The following is a description of a gene set: Somatic cells can be reprogrammed to a pluripotent state through the ectopic expression of defined transcription factors. Understanding the mechanism and kinetics of this transformation may shed light on the nature of developmental potency and suggest strategies with improved efficiency or safety. Here we report an integrative genomic analysis of reprogramming of mouse fibroblasts and B lymphocytes. Lineage-committed cells show a complex response to the ectopic expression involving induction of genes downstream of individual reprogramming factors. Fully reprogrammed cells show gene expression and epigenetic states that are highly similar to embryonic stem cells. In contrast, stable partially reprogrammed cell lines show reactivation of a distinctive subset of stem-cell-related genes, incomplete repression of lineage-specifying transcription factors, and DNA hypermethylation at pluripotency-related loci. These observations suggest that some cells may become trapped in partially reprogrammed states owing to incomplete repression of transcription factors, and that DNA de-methylation is an inefficient step in the transition to pluripotency. We demonstrate that RNA inhibition of transcription factors can facilitate reprogramming, and that treatment with DNA methyltransferase inhibitors can improve the overall efficiency of the reprogramming process. Genes with low-CpG-density promoters (LCP) bearing the bivalent tri-methylation marks at H3K4 (H3K4me3) and H3K27 (H3K27me3) in MCV8.1 cells (induced pluripotent cells, iPS). species: Mus musculus Mouse Gene Set: MIKKELSEN_IPS_LCP_WITH_H3K4ME3_AND_H3K27ME3 from publication Mikkelsen TS, Hanna J, Zhang X, Ku M, Wernig M, Schorderet P, Bernstein BE, Jaenisch R, Lander ES, Meissner A (PMID 18509334), and this is the list of marker genes: Cdh7, Fut7, Ppp1r26, Slc17a7, Slc16a8